Given this list of marker genes PUS1, KLF1, GLRX5, CDAN1, UROD, PIGA, HBB, CDIN1, LPIN2, SF3B1, GATA1, PGK1, UROS, TET2, LARS2, ABCB7, PKLR, CBLIF, SLC11A2, ERBB3, here is a description of the gene set: species: Homo sapiens Increased count of erythroid precursor cells, that is, erythroid lineage cells in the bone marrow. Human Gene Set: HP_ERYTHROID_HYPERPLASIA Erythroid hyperplasia